Given this list of marker genes HCG4, IL4 (NCBI Gene Id 3565), SRY, SI, TRPA1, MAGEA10, OLIG2, CASQ2, MSTN, ITPR2, CA12, CYP2E1, KCNA3 (NCBI Gene Id 3738), GPR183, SSX5, SLC6A4, PPFIA2, RPGRIP1 (NCBI Gene Id 57096), HSPB3, C3AR1, MAPK11, FUT9, NFKBIE (NFKB inhibitor epsilon), RAPGEF4, BMP6, THOC5, IL5RA, here is a description of the gene set: Genes in the cancer module 59. species: Homo sapiens Human Gene Set: MODULE_59